The following is a description of a gene set: Human Gene Set: GOBP_VENTRICULAR_CARDIAC_MUSCLE_TISSUE_MORPHOGENESIS studied in species Homo sapiens The process in which the anatomical structures of cardiac ventricle muscle is generated and organized., and this is the list of marker genes: ENG, POU4F1, NOTCH1, MED1, FOXC2, MYL3, NKX2-5 (NK2 homeobox 5), DSP, NRG1, CHD7, RYR2, NOG, RBPJ, MYH6, COL11A1, MYL2, PKP2, NAGLU, TNNI3, ISL1, TNNT2, FOXC1, HAND1, EDNRA, TGFB1, UBE4B, TGFBR1, HEG1, DLL4, LRP2, PTCD2, MYBPC3, TNNC1, SMAD7, BMP10, HEY2, TNNI1, PROX1, MYH7, TGFB2, FGFR2, ZFPM2, BMPR1A, FOXH1, TPM1, SMAD4, TGFBR3, FKBP1A